The following is a description of a gene set: Human Gene Set: GAVISH_3CA_METAPROGRAM_CD4_T_CELLS_UNASSIGNED species: Homo sapiens Genes upregulated in subsets of cells of a given type within various tumors from publication Gavish A, Tyler M, Greenwald AC, Hoefflin R, Simkin D, Tschernichovsky R, Galili Darnell N, Somech E, Barbolin C, Antman T, Kovarsky D, Barrett T, Gonzalez Castro LN, Halder D, Chanoch-Myers R, Laffy J, Mints M, Wider A, Tal R, Spitzer A, Hara T, Raitses-Gurevich M, Stossel C, Golan T, Tirosh A, Suvà ML, Puram SV, Tirosh I (PMID 37258682) In this study, an extensive analysis was conducted to define meta-programs (MPs) capturing intra-tumor heterogeneity across a spectrum of tumor types. The approach utilized non-negative matrix factorization (NMF) to analyze each cell type separately within individual tumor samples. This involved the analysis of malignant cells, macrophages, fibroblasts, endothelial cells, epithelial cells, T-cells, and B-cells. NMF was executed with varying parameter values (K=4, 5, 6, 7, 8, 9), thereby generating 39 programs for each cell type per sample. Each NMF program was summarized by the top genes based on NMF coefficients.\nRobust MPs were then delineated for each cell type using a set of stringent criteria, including recurrence within the same tumor, similarity to programs in other tumors, and non-redundancy within a tumor. Subsequently, these robust NMF programs were clustered (per cell type) based on Jaccard similarity, leading to the identification of MPs associated with each cell type.\nTo enhance the quality of the MPs, a refinement steps were undertaken, involving the removal of MPs suspected of reflecting low-quality data (with an overrepresentation of ribosomal proteins or mitochondrial-encoded genes), single-study inclusion, or similarity to miss-annotated cell types., and this is the list of marker genes: YWHAQ, LCP1, IFI27L2, PKM, NEDD8, CORO1B, TSPO, ID2, ISG15, S100A10, MT2A, DBI, APRT, LGALS1, PARK7, ATP5PF, UCP2, ALOX5AP, ARPC4, CAP1, PRDX1, TXN, LSP1, BBLN, CKLF, LY6E, BRK1, ANXA2, COPS9, KLRB1, PPP1CA, ANXA6, TRAPPC1, DAD1, S100A4, APOBEC3G, ARPC1B, CLIC1, LGALS3, ARPC5, SEC61G, LTB, CORO1A, EMP3, ANXA5, GZMA, COTL1, PSME2, LCK, PRELID1